Given this list of marker genes Cox8b, Cox6a1 (NCBI Gene Id 12861), Cyct, Cox8a, Cox4i1, Cox5b, mt-Co3, Cox5a, Cox4i2, Cox6a2, Afg1l, Cox7c, Cox7a1, Cox7a2, Cox7b2, Cox8c, Cycs, Cox7b, Cox7a2l, here is a description of the gene set: The transfer of electrons from cytochrome c to oxygen that occurs during oxidative phosphorylation, mediated by the multisubunit enzyme known as complex IV. Mouse Gene Set: GOBP_MITOCHONDRIAL_ELECTRON_TRANSPORT_CYTOCHROME_C_TO_OXYGEN studied in species Mus musculus